The following is a description of a gene set: The directed movement of L-leucine, 2-amino-4-methylpentanoic acid, into, out of or within a cell, or between cells, by means of some agent such as a transporter or pore. studied in species Mus musculus Mouse Gene Set: GOBP_L_LEUCINE_TRANSPORT, and this is the list of marker genes: Slc7a5, Slc43a1, Slc7a8, Llgl2, Slc6a15, Slc6a17, Slc7a7, Slc3a2, Slc43a2, Slc7a6